Given this list of marker genes DISC1, DSCAM, SLIT1, ADNP, MT3 (metallothionein 3), WNT3A, CDKL3, DIP2B, PAK1, PAFAH1B1, SEMA5A, ADCY10, NGF, NTRK3, ANAPC2, SIN3A, NTN1, GDI1, POU4F2, PUM2, WNT5A, CLASP2, DCC (NCBI Gene Id 1630), ISLR2, SEMA6D, MACF1, RAB21, SEMA3A, RNF6, TWF2, OLFM1, ABL1, NRCAM, SPP1, SHTN1, IST1, BCL11A, SEMA3F, NKX6-1, SEMA3G (NCBI Gene Id 56920), TTL, MAG, EFNA5, PLXNA3, CDH1, KIAA0319, GSK3B, LPAR3, ZFYVE27, L1CAM, CDK5, CRABP2, MAPT, HDAC6, SEMA4D, MAP1B, RTN4R, CXCL12, SEMA7A, DNM2, RUFY3, RGMA, RYK, NRP1, SEMA6C, TRPV2, DRAXIN, RND2, TRPC5, SMURF1, MAP3K13, BDNF, MAP2, EPHA7 (NCBI Gene Id 2045), VEGFA, TNFRSF12A, BARHL2, PLXNA4, GOLGA4, RTN4, WNT3, FSTL4, BMPR2, PTPRS (NCBI Gene Id 5802), SRF, CDH4, ULK1, LIMK1, IFRD1, TRIM46, SPART, MEGF8, TNR, FN1, CTTN (cortactin), ARHGAP4, APOE, CDKL5, ULK2, FGF13, SEMA4F, here is a description of the gene set: Human Gene Set: GOBP_REGULATION_OF_EXTENT_OF_CELL_GROWTH studied in species Homo sapiens Any process that modulates the extent of cell growth.